The following is a description of a gene set: The development, homeostasis and function of B lymphocytes involve multiple rounds of B cell receptor (BCR)-controlled proliferation and prolonged maintenance. We analyzed the role of transcription factor Zfx, a recently identified regulator of stem cell maintenance, in B cell development and homeostasis. Conditional Zfx deletion in the bone marrow blocked B cell development at the pre-BCR selection checkpoint. Zfx deficiency in peripheral B cells caused impaired generation of the B-1 cell lineage, accelerated B cell turnover, depletion of mature recirculating cells, and delayed T-dependent antibody responses. Zfx-deficient B cells showed normal proximal BCR signaling, but impaired BCR-induced proliferation and survival. This was accompanied by aberrantly enhanced and prolonged integrated stress response, and delayed induction of Cyclin D2 and Bcl-xL proteins. Thus, Zfx restrains the stress response and couples antigen receptor signaling to B cell expansion and maintenance during development and peripheral homeostasis. studied in species Homo sapiens Human Gene Set: GSE13547_2H_VS_12_H_ANTI_IGM_STIM_ZFX_KO_BCELL_DN from publication Arenzana TL, Smith-Raska MR, Reizis B (PMID 19329779) Genes down-regulated in B lymphocytes stimulated by anti-IgM: ZFX knockout (2h) versus wildtype (12h)., and this is the list of marker genes: NCAPG2, PAICS, RPL14, AHCY, SLC43A3, DNAJC15, IQGAP3, MT2A, PRTN3, MPO, IFNG, ITGB3, KIF11, ITGAX, E2F8, BRMS1L, GPNMB, HELLS, ATP8B4, TPI1, GGT1, DDX1, SDAD1, AP2S1, MKI67, CCR9, TUBGCP2, HMGN2, RAD51AP1, SPAG5, SERPINB9, CENPE, TPX2, NEIL3, IFNK, ATAD5, NSD2, IGF2BP3, KIF23 (kinesin family member 23), RPS25, PALS2, PSMD8, TAGLN2, ARHGAP11A, GINS1, ROM1, GALNT3, PLP2, CSF2, ARL6IP4, FMC1, RNPC3, CDC25C, NCKAP1, MELK (NCBI Gene Id 9833), TACC3, EXO1, MRPL1, DCK, BIRC5, DPY19L1, IPO5, PLK4, RRM2, TEX9, MIF, ARHGAP19, TOMM5, MAGI3, GMPS, GLRX, CCNB2, AURKB, EIF1AX, SEH1L, EXPH5, MAP3K8, DDX19A, CEP112, CDCA3, SNU13, RARS1, MYB, HMGB3, HOPX, MLF1, GTSF1, COX10, NEK2, CENPS, PRMT5, CRIP1, IRAK3, ORC1, RAP2C, MT1A, BLTP3B, PA2G4, ITGA1, MRPL20, GBP5, EMB, WDR36, MRPL48, IL18R1, ANXA2, KNL1, CPT1A, SATB1 (NCBI Gene Id 6304), HMMR, LGALS3, RRM1, MED12L, PHLDA1 (NCBI Gene Id 22822), KLF11, PTPN12, BBC3, CKS2, MRPL27, LEF1, ERAP1, TBC1D19, PRELID1, RPF2, ADSS2, SMC2, KLRK1, TFRC, BANF1, MRPL18, CCR2, SGO2, SYCE2 (synaptonemal complex central element protein 2), MTFR2, BRIP1, MIX23, TMPO, SNX5, VIM, PMF1, KIF15, ACAA2, SEC61B, IL2RA, RBM3, RIDA, SAE1, IL1RL1, CXCL9, NDUFB7, NRM, CCDC18, YBX1, MCM10, CEP89, TUBG1, RACGAP1, GLIPR2, ESM1, LGALS1, DEPDC1B, CENPH, CDC6, B3GNT2, CCDC50, TMBIM4 (transmembrane BAX inhibitor motif containing 4), PTPN6, INTS2, CLIC1, LRWD1, PLAC8, KMT5A, CENPF, CEP83